The following is a description of a gene set: Human Gene Set: REACTOME_FCERI_MEDIATED_MAPK_ACTIVATION studied in species Homo sapiens FCERI mediated MAPK activation, and this is the list of marker genes: IGLV2-23, VAV1, IGKV3-15, KRAS, SYK, IGKV1-33, IGHE, IGHV3-7, MAPK8, IGLC3, IGKV3-11, IGHV3-33 (immunoglobulin heavy variable 3-33), IGHV3-13, IGKV1D-39, IGLV1-40, IGLV1-47, IGHV3-23, IGKV1D-16, IGLV6-57, IGKV3-20, IGHV4-59, IGLV2-8, MAPK1, LCP2, IGKV1-39, IGKV1-17, MAPK10, PAK2, MAPK3, IGKV1-12, IGLV3-21, IGHV1-2, IGHV4-39, IGHV2-70, IGKV2-30, IGLV7-43, LAT, IGLV3-27, MAP3K1, FCER1G, GRB2, IGHV3-30, IGKV5-2, IGKV1D-12, MAP2K4, IGKV2D-40, IGLV1-51, PLCG2, IGKV3D-20, IGLC2, FOS (NCBI Gene Id 2353), IGKV1-16, JUN (NCBI Gene Id 3725), HRAS, IGHV1-46, IGHV3-48, PLCG1, GRAP2, IGLV2-11, MAPK9, IGKV1-5, IGHV1-69 (immunoglobulin heavy variable 1-69), NRAS, MAP2K7, IGKV1D-33, SHC1, IGKV2D-28, IGHV2-5, SOS1, RAC1, IGKV2-28, IGLV3-25, VAV3, IGLV1-44, IGHV3-53, IGLV3-19, LYN, IGKV2D-30, FCER1A, IGLV2-14, IGKV4-1, IGHV3-11, PAK1, MS4A2, VAV2, IGHV4-34, IGLV3-1